Given this list of marker genes PALS1, TSPAN14, OLFM1, CACNA2D3, L3MBTL3, GRM7, BAAT, PNPLA3, SIK2, PRTG, GSG1L, INPP4B, ZNF213, ZNF569, CNTNAP2, PER2, IL21, ZNF37A, TMEM33, CGN, RALBP1, MS4A3, HTR7, ELF1, FCER1A, ARMS2, SLC38A1, POGK, BNC2, TMTC1, LMLN, ACVR1, NADSYN1, CST9, ITGB8, ZNF655, ZDHHC3, SLC8A2, KLHDC8A, LINGO3, CASP8AP2, HYDIN, PDIK1L, TNRC6C, ZDHHC15, KBTBD8, PDLIM4, XPR1, PTPRK, FAM135B, SNCA, STUM, CDIN1 (NCBI Gene Id 84529), CASQ2, KCNB1, ADCY1, PSMF1, C3AR1, RMI2, LRP1B, CD38, SLC22A15 (NCBI Gene Id 55356), SH3TC2, MRPL45, SACS, AHCYL2, SOX6, NPVF, DPP4 (dipeptidyl peptidase 4), TRIM67-AS1, TSSK1B, ACP1, PPP4R3A, MEGF11, TMOD2, LRRC8B, MYLK4, FAM107B, ZNF75A, WFDC10B, SALL1 (NCBI Gene Id 6299), RAB43, HLF, VSIG1, UBE2D3, PRDX6, CST9L, PTN (NCBI Gene Id 5764), ZNF184, ARL5B, RHOG (NCBI Gene Id 391), TBR1, CD1B, TLR1, BORCS7, GTF2H1, C6orf118, IDE, GAS8, here is a description of the gene set: from publication Chen Y, Wang X (PMID 31504780) Genes predicted to be targets of miRBase v22 microRNA hsa-miR-8075 in miRDB v6.0 with MirTarget v4 prediction scores > 80 (high confidence targets). Human Gene Set: MIR8075 studied in species Homo sapiens